The following is a description of a gene set: studied in species Mus musculus Catalysis of the reaction: a primary methyl amine + H2O + O2 = an aldehyde + H2O2 + NH4+. Mouse Gene Set: GOMF_PRIMARY_METHYLAMINE_OXIDASE_ACTIVITY, and this is the list of marker genes: Aoc1l1, Aoc3, Dao, Maoa, Aoc1l2, Aoc2, Ddo, Maob, Aoc1l3, 4930438A08Rik, Vcam1, Aoc1, Il4i1, Lao1